Given this list of marker genes RAB10, LAMA2, ODC1, TXNRD1, CYBB, CEBPB, CD79A, RAB20, CAT, HINT1, CYB5A, PRKCD (protein kinase C delta), ADAM17, HSPD1, MTHFD2, PLEKHA1, PRKAB1, CLEC12A (NCBI Gene Id 160364), UPP1, SLCO3A1, FSCN1, RTN2, TRAF3IP2, CST7, MARCKSL1, CEMIP2, RBPMS, SLC1A2, TRAF1, CCDC50, PGAP2, CXCR6, KLF7, MRPL54, CD80, SLC6A12, MRAS, FGL2, RNF149, IGF2BP2, PTPN2, LCN2, SMS, LANCL3, PTPRJ, IGFBP7, HEG1, SLAMF6, ETS1, MRPL52, LPP, NFKBIA, FLNA, SDC4, LCP2, PTGR3, FAS, TNFRSF1B, HIF1A, CX3CL1, CD40, ADK, IFITM2, ARHGAP31, ADGRG6, MORF4L2, C3, EAF1, DUSP16, SIK1, TLR1, VTI1A, ATF4, STAT1, IL36G, PGK1, FCMR, LY75, JAKMIP1, RILPL2, DGAT2, LIMS1, ADGRL2, INHBA, ICAM1, TES, IL2RG, RIMS3 (regulating synaptic membrane exocytosis 3), LST1, PIK3R6, NPLOC4, TARM1, NOP58, PTTG1IP, EBI3, EEIG2, NQO1, WDR1, GSTM3, RAPGEF5, IL12B, TXNDC17, GSAP, PPIC, STK40, PDE4B, EVA1B, ANPEP, SPACA6, HPN, VCAN, FAM114A1, CDC42EP2, SRXN1, STAT4, ZC3H12A, IFT57, TLR2, MLKL, RELB, PRKAR2B, KMO, NAB1, SLAMF7, RIGI, CD36, CD69, PID1, N4BP1, SRC, CD300LD, S100A9, SERP1, SCHIP1, CD83, ITGA4, FCRL5, RAP1GAP2, LAD1, MMP14, DTX2, RALGDS, CBLN1 (NCBI Gene Id 869), SLC7A2, CAV1, DENR, LY6D, SQSTM1, CPD, NLRP3, TMEM26, CMTM3, TPM4, F10, CMPK2, CFLAR, FLRT3 (NCBI Gene Id 23767), MEFV, ANTXR1, MAPKAPK2 (NCBI Gene Id 9261), SAMSN1, NXPE3, PSMD8 (NCBI Gene Id 5714), MS4A1, USP18, VCL, KCNA3 (NCBI Gene Id 3738), PDE7B, PIK3R5, JAK2, SLC13A3, ME1, PFKFB3, KRTCAP2, CEP83 (NCBI Gene Id 51134), PROCR, ST7, here is a description of the gene set: Genes down-regulated in memory CD8 T cells: 3' versus 4'. studied in species Homo sapiens The transcriptome of naive OT-I T cells was compared to memory CD8 T cells after 1, 2, 3, or 4 infection with ovalbumin expressing Listeria monocytogenes (LM-OVA). from publication Wirth TC, Xue HH, Rai D, Sabel JT, Bair T, Harty JT, Badovinac VP (PMID 20619696) Human Gene Set: GSE21360_TERTIARY_VS_QUATERNARY_MEMORY_CD8_TCELL_DN